Given this list of marker genes TUBA3C, TUBAL3, TUBB6, CCT7, PFDN4, PFDN2, TUBB4B, VBP1, TUBA4B, TUBB3, CCT6A, PFDN6, TUBA1A, PFDN5, CCT3, TUBA3D, PFDN1, TUBB2A, TUBA1B, CCT8, TCP1, TUBB1, TUBA3E, ACTB, CCT4, TUBA8, TUBA4A, CCT2, TUBB2B, CCT6B, CCT5, TUBA1C, TUBB4A, here is a description of the gene set: part of: Chaperonin-mediated protein folding studied in species Homo sapiens In the case of actin and tubulin folding, and perhaps other substrates, the emerging polypeptide chain is transferred from the ribosome to TRiC via Prefoldin. Reactome Pathway: Cooperation of Prefoldin and TriC/CCT  in actin and tubulin folding